Given this list of marker genes IGLV1-50, IGHV1-2, RABGAP1L, IGHV2-26, IGLV2-18 (NCBI Gene Id 28814), IGKV2D-29, IGKV2D-30, PTEN, GADD45A, SEMA3E, PTPN22, JCHAIN, MINPP1, IGHV1-24, HPGD (15-hydroxyprostaglandin dehydrogenase), ESR1, CA2, NFKBIA, IGHA2, IGKV5-2, ITIH1, IGKV4-1, IGKC, MBTD1, here is a description of the gene set: species: Mus musculus Human infertility and recurrent pregnancy loss caused by implantation defects are poorly understood. Hoxa-10-deficient female mice have severe infertility and recurrent pregnancy loss due to defective uterine implantation. Gene expression profiling experiments reveal that Hoxa-10 is an important regulator of two critical events in implantation: stromal cell proliferation and local immunosuppression. At the time of implantation, Hoxa-10 mediates the progesterone-stimulated proliferation of uterine stromal cells. Hoxa-10 mutants express a stromal cell proliferation defect that is accompanied by quantitative or spatial alterations in the expression of two cyclin-dependent kinase inhibitor genes, p57 and p15. Hoxa-10 deficiency also leads to a severe local immunological disturbance, characterized by a polyclonal proliferation of T cells, that occurs in place of the normal progesterone-mediated immunosuppression in the periimplantation uterus. Human Gene Set: YAO_TEMPORAL_RESPONSE_TO_PROGESTERONE_CLUSTER_3 Genes co-regulated in uterus during a time course response to progesterone: SOM cluster 3. from publication Yao MW, Lim H, Schust DJ, Choe SE, Farago A, Ding Y, Michaud S, Church GM, Maas RL (PMID 12554760)